Given this list of marker genes Junb, Rgs2, Fos, Dusp1, Uba52, here is a description of the gene set: Mouse Gene Set: CUI_TREG_IL22_RESPONSE_DN studied in species Mus musculus Cytokines mediate cell-cell communication in the immune system and represent important therapeutic targets. A myriad of studies have highlighted their central role in immune function, yet we lack a global view of the cellular responses of each immune cell type to each cytokine. To address this gap, the authors created the Immune Dictionary, a compendium of single-cell transcriptomic profiles of more than 17 immune cell types in response to each of 86 cytokines (>1,400 cytokine-cell type combinations) in mouse lymph nodes in vivo. A cytokine-centric view of the dictionary revealed that most cytokines induce highly cell-type-specific responses. For example, the inflammatory cytokine interleukin-1β induces distinct gene programmes in almost every cell type. A cell-type-centric view of the dictionary identified more than 66 cytokine-driven cellular polarization states across immune cell types, including previously uncharacterized states such as an interleukin-18-induced polyfunctional natural killer cell state. Genes negatively differentially expressed in cell type: Treg upon treatment with cytokine: IL-22 in mouse lymph nodes in vivo. from publication Cui A, Huang T, Li S, Ma A, Pérez JL, Sander C, Keskin DB, Wu CJ, Fraenkel E, Hacohen N (PMID 38057668)